The following is a description of a gene set: Human Gene Set: GSE25088_WT_VS_STAT6_KO_MACROPHAGE_ROSIGLITAZONE_STIM_DN Genes down-regulated in bone marrow-derived macrophages treated with rosiglitazone: wildtype versus STAT6 knockout. species: Homo sapiens from publication Szanto A, Balint BL, Nagy ZS, Barta E, Dezso B, Pap A, Szeles L, Poliska S, Oros M, Evans RM, Barak Y, Schwabe J, Nagy L (PMID 21093321) C57Bl/6 wild-type and STAT6 KO mice were used to study PPARg and IL-4 signaling. Bone marrow of 3 mice per group was isolated and differentiated to macrophages with M-CSF (20 ng/ml). 20 ng/ml IL-4 was used to induce alternative macrophage activation and 1 uM Rosiglitazone (RSG) was used to activate PPARg. From each mouse 4 samples were generated: 1. M-CSF, 2. M-CSF+RSG, 3. IL-4 and 4. IL-4+RSG. All compounds were added throughout the whole differentiation process, and frech media was added every other day. Control cells were treated with vehicle (DMSO:ethanol). After 10 days, RNA was isolated and gene expression profiles were analyzed using Mouse Genome 430 2.0 microarrays from Affymetrix., and this is the list of marker genes: VEGFC, DLL4, ALDOC, THY1, NRXN2, LYNX1, VAV2, MRGPRG, TPPP, SMS, TNIP1, KLRK1, YPEL5, HRH1, TIFA, ABLIM2, POLR3B, HERC2, PEX2, PRKAG2, MAP1LC3B, FOXRED2, RORC, SYN1, GPR37, KDM7A, ACADSB (NCBI Gene Id 654185), CDK14, HMGN3, AP3M2, MKS1, UCKL1, NPVF, RALGPS1, GPR35, MBD5, PDXK, MMP10, SELENOO, SLAMF6, TMEM127, PTPRC, ZEB2, RABEP2, FAM174A, SHARPIN, PELI1, WARS2, ZFYVE1, PHLPP2, SP1, ADAMTS6, EZH1, CDC42BPG, ITGB3, VPS50, HS3ST3B1, C1orf198, RASSF4, PINK1, FOXO1, KIAA0825, APPL2, BTBD8, SCAI, IRAK2, OSTM1, XBP1 (X-box binding protein 1), SQLE, SLC27A1, VPS39, UBL3, INPP4A, PPP1R3G, MESD, TTC19, MYCL, FANCD2OS, TUBGCP5, MEAK7, SLC35D2 (NCBI Gene Id 11046), ATXN7L3B, VPS26A, RCBTB1, CLDND1, SENP6, GATC, ARPC5, DDI2, FLNB, TMEM218, MMAA, SEMA4C (semaphorin 4C), RNASE6, TSPYL4, N4BP2L2, KIZ (NCBI Gene Id 57166), DAP, CNTN6, GPR25, THNSL1, AP1M2, TMOD3, LINC01160, STAT2, RNF146, EIF4A2, ACTB, ATP1B3, PURG, PURA, TENM1, IRF1, SENP7, UFL1, ACTRT2, KANK2, SPATA9, B3GNT9, RPL39, DUSP5, PRKRA, SIGLEC10, PLTP, EPSTI1, TRAPPC6B, MAN1C1, LDLRAD3, LGR5, SPNS3, EPB42, SBSPON, TNFAIP8, CNOT8, RALGAPA1, PPP3CA, RGL1, USO1, C12orf75, INO80D, PLEKHB2, FGD6, H3C7, ZDHHC9, PTK2, ADGRE5, KMT2E, KCTD12, STOML1, NFKB1, ATP8B1, CYBB, SDCCAG8, CD53, PDE7A, TAOK1, CHD9, XRCC4, VAMP1 (vesicle associated membrane protein 1), KLHL18, ADORA3, ZMIZ1, IGLC7, NOCT, SYNPO, TFRC, TRAPPC5, PTS, MTCL2, CTNNA1, WRN, ZFYVE21, HLA-E, ITGAL (NCBI Gene Id 3683), SLC35D3, SARAF, CALCOCO1, SLA2, EPHA2, AIF1L, LMAN2L, C2orf88, AHI1, CTSW, RAP1A, DGKE, RELL1, PRR5L, BET1 (NCBI Gene Id 10282), SLC38A9, TMEM86A, UTY, SAV1, FBXL12, RBM5, XIAP, SLFN13, TRMT1L, DNAJC4, APBA1